Given this list of marker genes CCR5, CIT, GPN1, CCL4, GJA1, NTMT1, NFIL3, NDRG2, FBXO21, PROCR, HLX, TMEM40, GADD45G, NOCT (NCBI Gene Id 25819), DNM1L, STK19, CXCL9, SMOC1, CHCHD6, H1-0, SLC41A1, TNKS2, RBPJ, PSMD5, PPP1R15A, IMP4, HPS4, FCGR2B, TTC27, TMEFF1, CSF2RB, SELE, SLC22A5, PCK1, IL4R, PSTPIP2, POU1F1, BHLHE40, BATF, CDKN2D, NSMCE3, EMP1, TARS2, TMEM268, AMBP, SMAD3, SUSD6, MYD88, AGFG1, MED12L, TNFRSF1A, RPF1, TCP11, LTBP1, MCOLN2, PXMP2, MEMO1, UBE3A, MC1R, PTGER4, NSMCE1, CCR1, PHLDA3, CACNG1, ALG2, UTP4, COL10A1, H1-2, RHOH, BACH1, F2RL3, BZW2, SELP, ITGB5, AMACR, CXCL10, TBX6, SOCS3, UBC, SLC30A9, GBP4, MAP2K1, CCDC186, NEU1, FEZ2, CBX7, CMTM6, ZNF703, SAA1, SEMA6B, B4GALT3, RCAN1, GORASP2, PHGDH, ELOVL1, NUP50, GCM1, CALU, MAP3K1, MAFB, TSSK1B, GADD45A, EIF6, GBX2, SH3GLB1, MIDN (NCBI Gene Id 94034), USP22, CEP350, TBP (TATA-box binding protein, NCBI Gene Id 6908), SEMA6D, GMCL1, ADAR, POSTN, DDX51, INHBE, CSF3R, EDNRB, IL6, WDR77, BMPR1B, PCTP, ELAVL4, BIRC3, R3HCC1, MT1E (NCBI Gene Id 4493), DCK, CALML4, ST8SIA3, SLC35E4, NFYB, GDE1, NDUFS6, HLA-E, TAT, EMB, NT5C3B, PAX2, CH25H, MIS18BP1, NKX2-3, FGL2, NPHP1, ZFAND5, AIMP1, ELP5, IRF1, LGALSL, CLDN1, JAK2, HDAC2, IL1RN, B4GALT6, XRCC5, NDUFS4, EEF2, ERRFI1, KAZALD1, IGFBP1, IL17RA, PEX2, IL5RA, PRKAR1B, SDHD, UGT2B10, DKK1, BTRC, CEBPD, CA2, HTR2C, RNF149, COQ3, MT2A, HCK, NAGK, HNF4G, HDHD2, CYP4A11, RGCC, DUSP16, NHSL3, RASD1, LITAF, MX1, AHI1, RAB3IL1 (NCBI Gene Id 5866), PLSCR1, SPHK1, THAP7, PTPN1, SOCS1, CD86, ATP5IF1, WDHD1, GSDME, CDH5, MAP3K8, NOC4L, AIP, THBD, PKIG, here is a description of the gene set: from publication Yosef N, Shalek AK, Gaublomme JT, Jin H, Lee Y, Awasthi A, Wu C, Karwacz K, Xiao S, Jorgolli M, Gennert D, Satija R, Shakya A, Lu DY, Trombetta JJ, Pillai MR, Ratcliffe PJ, Coleman ML, Bix M, Tantin D, Park H, Kuchroo VK, Regev A (PMID 23467089) Human Gene Set: GSE43955_TH0_VS_TGFB_IL6_TH17_ACT_CD4_TCELL_1H_UP studied in species Homo sapiens Despite their enormous importance, the molecular circuits that control the differentiation of Th17 cells remain largely unknown. Recent studies have reconstructed regulatory networks in mammalian cells, but have focused on short-term responses and relied on perturbation approaches that cannot be applied to primary T cells. Here, we develop a systematic strategy – combining transcriptional profiling at high temporal resolution, novel computational algorithms, and innovative nanowire-based tools for performing gene perturbations in primary T cells – to derive and experimentally validate a temporal model of the dynamic regulatory network that controls Th17 differentiation. The network is arranged into two self-reinforcing and mutually antagonistic modules that either suppress or promote Th17 differentiation. The two modules contain 12 novel regulators with no previous implication in Th17 differentiation, which may be essential to maintain the appropriate balance of Th17 and other CD4+ T cell subsets. Overall, our study identifies and validates 39 regulatory factors that are embedded within a comprehensive temporal network and identifies novel drug targets and organizational principles for the differentiation of Th17 cells. Genes up-regulated in CD4 T helper cells (1h): Th0 versus TGFB1 and IL6.